The following is a description of a gene set: from publication Lui WO, Foukakis T, Lidén J, Thoppe SR, Dwight T, Höög A, Zedenius J, Wallin G, Reimers M, Larsson C (PMID 15608688) Cluster 3: genes with similar expression profiles across follicular thyrorid carcinoma (FTC) samples; genes in this cluster correlated well with the presence of PAX8-PPARG fusion protein. Human Gene Set: LUI_THYROID_CANCER_CLUSTER_3 The demonstration of the PAX8-PPAR(gamma) fusion oncogene in a subset of follicular thyroid tumors provides a new and promising starting point to dissect the molecular genetic events involved in the development of this tumor form. In the present study, we compared the gene expression profiles of follicular thyroid carcinomas (FTCs) bearing a PAX8-PPAR(gamma) fusion against FTCs that lack this fusion. Using unsupervised clustering and multidimensional scaling analyses, we show that FTCs possessing a PAX8-PPAR(gamma) fusion have a highly uniform and distinct gene expression signature that clearly distinguishes them from FTCs without the fusion. The PAX8-PPAR(gamma)(+) FTCs grouped in a defined cluster, where highly ranked genes were mostly associated with signal transduction, cell growth and translation control. Notably, a large number of ribosomal protein and translation-associated genes were concurrently underexpressed in the FTCs with the fusion. Taken together, our findings further support that follicular carcinomas with a PAX8-PPAR(gamma) rearrangement constitute a distinct biological entity. The current data represent one step to elucidate the molecular pathways in the development of FTCs with the specific PAX8-PPAR(gamma) fusion. studied in species Homo sapiens, and this is the list of marker genes: HINT1, ATP5F1A, ERGIC3, LITAF, ATXN10, CLDN7, ITM2B, FBL, RPS5, RPL18, UBE2E3, RPS12, HSP90AB1, UQCR11, SARS1, TMEM147, RPL17, RPL21, RPS2, EIF3F, EIF3G, PSMD8, RPL18A, RPL10A, EIF3K, HSPA8, TMBIM6 (transmembrane BAX inhibitor motif containing 6), RTN4 (NCBI Gene Id 57142)